Given this list of marker genes CFAP221, TTLL1, STARD7, NEK10, DRC1, ODAD4, SPAG16, CFAP43 (NCBI Gene Id 80217), DNAH9 (NCBI Gene Id 8709), VANGL1, CCDC88C, CFAP54, here is a description of the gene set: Human Gene Set: GOBP_MUCOCILIARY_CLEARANCE The respiratory system process driven by motile cilia on epithelial cells of the respiratory tract by which mucus and associated inhaled particles and pathogens trapped within it are moved out of the airways. studied in species Homo sapiens